Given this list of marker genes SDHD, LAS1L, SEMA3E, NHLH2, SLCO2A1, CUL4B, MAP3K1, AFF4 (NCBI Gene Id 27125), HPGD, CDH23, AKT2, SDHB, SEMA3A, RBM28, LHB (luteinizing hormone subunit beta), WDR11, STK11, FGF8, FMR1, NR0B1, RSPO1 (NCBI Gene Id 284654), NDNF, CYB5A, PHF6, WT1, PROKR2, MEN1, FGF17, PROK2, SEC23B, ZFPM2, DHX37, HESX1, FLRT3, SCN4A, KLLN, ANOS1, RNF216, AXL, FEZF1, SMCHD1, COQ8A, USF3, TACR3, HFE, PTEN, PIK3CA, BMP6, NSMF (NCBI Gene Id 349336, NMDA receptor synaptonuclear signaling and neuronal migration factor), ZBTB20 (NCBI Gene Id 26137), GNRH1, PNPLA6, IL17RD, DES, MECP2, POLR3A, SDHC, SH3PXD2B, PRKAR1A, GNRHR, TCF20, CYP11A1, HDAC8, SRA1, NR5A1, DCC, KISS1, HSD17B3, TAC3, TMEM53, CYP11B1, GATA4, ITGA3, CPE, SOX9, SOX10, ERMARD, PSMB8, CHD7, CYP21A2, AKT1, LEP, DUSP6, LEPR, PDE11A, TTI1, VAMP7, CYP17A1, AR, SPTBN1, CCDC141, ALMS1, SRY, HS6ST1, SMC5, SPRY4, PLAAT3, HSD3B2, KISS1R, SLC29A3, FGFR1, AIP, WWOX, here is a description of the gene set: Abnormal development of large mammary glands in males resulting in breast enlargement. Gynecomastia Human Gene Set: HP_GYNECOMASTIA studied in species Homo sapiens